The following is a description of a gene set: Any process that modulates the frequency, rate or extent of cellular response to vascular endothelial growth factor stimulus. species: Homo sapiens Human Gene Set: GOBP_REGULATION_OF_CELLULAR_RESPONSE_TO_VASCULAR_ENDOTHELIAL_GROWTH_FACTOR_STIMULUS, and this is the list of marker genes: MIR424, PIK3CB, ITGA5, ADAMTS3, MIR199A1, PROX1, HRG, SEMA6A, TSPAN32, MIR329-1, CCBE1, SMOC2, DAB2IP, ROBO1, TNXB, ADGRA2, SPRY2, ITGB3, MIR16-1, DLL1, GREM1, ATP2B4, IL12B, ITGB1, VEGFA, EMILIN1, VTN, ADAMTS12, NR2F2, ANGPT1, JCAD, PTP4A3, DCN, MIR21, ADGRG1, CD63, CADM4, MIR342, IL12A